The following is a description of a gene set: CD25+ regulatory T cells develop in the thymus (nTregs), but may also be generated in the periphery upon stimulation of naive CD4 T cells under appropriate conditions (iTregs). The mechanisms that regulate the generation of peripheral iTregs are largely unknown. We used microarrays to gain insights into the molecular program of extrathymic Treg development. Human Gene Set: GSE24634_NAIVE_CD4_TCELL_VS_DAY5_IL4_CONV_TREG_UP species: Homo sapiens Genes up-regulated in comparison of naive T cells at day 0 versus CD25+ regulatory T cell (Treg) treated with IL4 at day 5. from publication Prots I, Skapenko A, Lipsky PE, Schulze-Koops H (PMID 21347372), and this is the list of marker genes: ZBTB18, RPL19, HAUS3, PIP4K2B, ELF2, ATXN7, CXXC1, CBFA2T2, ZNF589, SLC25A36, RNF139, JMJD1C, MGAT4A, RNF125, PARP8, PARP16, FHIT, FAM8A1, ZBTB1, DNAJC22, CRISPLD2, SLC16A6, ANKRD12, SRSF5, P2RY10, NFKBIA, ABCA7, AMH, ECHDC2, ZSWIM8, WNT10B (NCBI Gene Id 82499), CCSER2, THUMPD1, GVINP1, RNF130, GADD45B, BMAL1, NGRN, KBTBD2, ITGA6, PTGER1, ITIH3, BACH2, CD55, SYNE1, MST1, FOXN3, STK19, STX16 (NCBI Gene Id 8675), GTF2F1, BCL11B, RPL28, ISG20, TRIM22, MX2, RAB25, GALNT12, RPL32, RPL34, MSL2, REX1BD, CBLB (Cbl proto-oncogene B), TAS2R10, ZNF669, CD247 (CD247 molecule), RPL29, TCTA, ZNF165, RHOH, CLK1, MRC2, POM121 (NCBI Gene Id 9883), IQCK, TPST1 (tyrosylprotein sulfotransferase 1), TOB1, TMUB2, BHMT, TENT5C, ZNF34, SMARCD3, RPS10, BCL6, TMEM260, BIN2, HECA (NCBI Gene Id 51696), MAST3 (NCBI Gene Id 23031), GPR75, ZBTB16, NCOA2, TMPRSS5, CLK4, TRIM10, MXI1, JADE1, PLEKHB1, PGGHG, MVK, RBFOX1, IFT20, MAGED2, ZC3H12A, GPR153, PQBP1, KANSL2, TMEM161A, AMT (aminomethyltransferase), GOLGA8H, ABLIM1, CD27, RPS14, RPL11, ATP6V1G2, ZSCAN18 (zinc finger and SCAN domain containing 18), PSPN, RNF38, RNF220, USE1, ID4, KAT8, IL23A, NME3, BCL2, SGSH, ZBTB20, CYTIP, NLRP1, FOXO1, LBH, PPP2R2D, PEX5L, TENT5A, DAZAP2, CD69, ANKRD6, FAM53C, ZNF551, LITAF, NBPF10, ATP8A1, PRKCZ, GUSBP14, NTF3, PACS1, GRB7, JAM3, FGF9, SETD2, SAMHD1, ZFAND3, RPL35A, SGF29, ADGRL1, MTERF4, DGKZ, PRKAB2, CDK6, ZNF665, ANGPTL2, HLA-F, IL11RA, CMKLR2, CD248, DCAF16, SNX6, SNN, KAT6B, SARDH, ZNF44, ATP6V1G1, BTN3A1, SH2B2, RPL10L, CHKB, ZBTB40, COX4I1, HLA-E, SMURF2, LEPROTL1, CHST12, SCAND1, CYTH1, ATG14, TRAPPC6A, ULK2, ANKRD49, CFAP74, PEPD, NYNRIN, GFOD3P, SPSB3, CTSF, SLC2A11, NOL12, SLC4A1, RSRP1, ZNF510, FAM171A1, MGP, CDR2, GALNT11